The following is a description of a gene set: from publication Qi Q, Cavanagh MM, Le Saux S, Wagar LE, Mackey S, Hu J, Maecker H, Swan GE, Davis MM, Dekker CL, Tian L, Weyand CM, Goronzy JJ (PMID 27764254) species: Homo sapiens Vaccination with attenuated live varicella zoster virus (VZV) can prevent zoster reactivation, but protection is incomplete especially in an older population. To decipher the molecular mechanisms underlying variable vaccine responses, T- and B-cell responses to VZV vaccination were examined in individuals of different ages including identical twin pairs. Contrary to the induction of VZV-specific antibodies, antigen-specific T cell responses were significantly influenced by inherited factors. Diminished generation of long-lived memory T cells in older individuals was mainly caused by increased T cell loss after the peak response while the expansion of antigen-specific T cells was not affected by age. Gene expression in activated CD4 T cells at the time of the peak response identified gene modules related to cell cycle regulation and DNA repair that correlated with the contraction phase of the T cell response and consequently the generation of long-lived memory cells. These data identify cell cycle regulatory mechanisms as targets to reduce T cell attrition in a vaccine response and to improve the generation of antigen-specific T cell memory, in particular in an older population. Human Gene Set: QI_PBMC_ZOSTAVAX_AGE_50_75YO_CORRELATED_WITH_CONTRACTION_OF_VZV_SPECIFIC_T_CELLS_PEAK_TO_28DY_AT_1DYPOSITIVE Genes positively correlated with contraction of VZV specific T cells (peak to 28d) in peripheral blood mononuclear cell in seniors (50-75) after exposure to Zostavax, time point 1D, and this is the list of marker genes: TM2D3, MYH9, WAC, TMEM140, ERGIC1, DPYD, SOD2, ADPRS, HLA-DRB3, DENND5A, TSC22D3, NIBAN1, TMBIM1, RFTN1, SARAF, GABARAPL2, SELL, GPC1-AS1, SEC14L1, ACAP2, AMY2A, SMNDC1 (survival motor neuron domain containing 1), FOXO3, KHDC4, ATP6V1B2, PCBP1, POGK, CLINT1, NOTCH1, ALDH2, TOMM20, RNF40, CAP1, ITGB2 (NCBI Gene Id 3689), WAS, LRRK2, TMEM179B, NAAA, MAN2B2, LILRA6, KDM3B, CTNNA1, BANP, CXCR2, ANTXR2, WBP2, TMED7 (NCBI Gene Id 51014), PRR13, PPT1, RBM47, RERE (arginine-glutamic acid dipeptide repeats), SIGLEC10, RNF114, GRN, ARAP3, NCOA4, RNF103, NARF, TALDO1, VPS26B, ZHX2, HHEX, PGAM1, KDM2B, RNASET2, UBAP1, SDF4, TLR1, GATD3, CAMK2G, THUMPD1, PCMTD1, IST1, PPP1R21, MTMR3, EFTUD2, CYBB, NUP93, CITED2, LIMS1, FRAT1, HNRNPA2B1, CLEC16A, PSMB10, SH3GLB1, FNBP1, TIPARP, UVSSA, RNF130, HDAC1, RNF149, DNAJB6 (NCBI Gene Id 9186), PTBP1, ESS2, MYADM, CREBBP, CYSLTR1, MED16, SH3KBP1, HMGB2, L3MBTL2, ZNF217, ADD1, PRKCB, NFE2, PPP4R1, RBL2, RTF2, CD14, RAB11FIP1, SPEN, DIP2B, WDR1, MARCKS, ALOX5 (NCBI Gene Id 240), IRF2BP2, TRIP12, UBA7, LCP1, RIPOR1, KIF5B, CPQ, ST6GAL1, POTEF, CHST15, WDR37, TAGLN2, SLCO3A1, SMAP2, MORC2-AS1, PARP1, NPL, CFAP58, RBM33, NABP1, SELENOS, TMEM87A, SHCBP1, FGR, ROCK2, GNAI2, TLR4, DCAF12 (DDB1 and CUL4 associated factor 12), ST13P4, TUBB, TTC27, HERPUD1, AP1M1, CALM2, YIPF6, SLC6A6, CPSF1, YBX3, ZC3H7A, GAB2 (NCBI Gene Id 9846), RB1CC1, PGRMC2, ITGB1BP1, MTMR14, ABHD5, RNF13 (NCBI Gene Id 11342), CLIC4, CD300A, CMIP, TNFRSF1A, NACA, SERF1B, TMEM158, PLSCR1, GDI2, ZC3H4, SRSF5, FNDC3B, RNF34, MORF4L1, EIF4E3, FBXO33, PGAM4, TRMT5, ZC3HAV1, SIGLEC14, IK, RNF19A, CTDSP2, CAPNS1, TNFRSF1B, RNF145, CDC42, JARID2, ERICH1, ADGRE5, VSIR, IGF2BP2, CAB39, RXRA, RAC2, SPAG9, TXK, RHOG, STX4, GTPBP4, ZMIZ1, CYBA, CD300LF, ADGRE2, CPVL, WLS, AKIRIN2, EIF4A3, YWHAB, HARS2, LPAR2, RUNDC1, STAT3, PDE7A, ZFAND5, ARHGDIB, HLA-DRA, PSAP, CHD1, BTF3, RALBP1, TGFBR2, SLA, BTN2A1, NCOA1, SLC7A5, JAK1, FOS, LRP10, SGK1, CCR2, BNIP3L, RESF1, CLNS1A, EIF3L, IFIH1, PSME4, PLCG2, GAS7, ARHGAP25, SDE2, PCBP2, MLKL, CYTIP, HSPA1A, NKTR, NCF1C, SP3, ELF2, MMP25, ARHGAP30, TRIM58, HCFC1, UBE3C, RAB24, TFDP1, PRKCD, SCAF11, RAF1, GAB3, SERPINA1, ADGRE3, FBXO7 (F-box protein 7), EMILIN2 (elastin microfibril interfacer 2), PTBP3, HLA-B, DCAF7, PDLIM7, PHIP (NCBI Gene Id 83843), DERL1, GLB1, B4GALT5, FCGR3B, TNFAIP6, LMO2, SON, GIMAP8, NUCB1, ARF1, TACC1, TCN1, ARID1A, EXO5, IWS1, NOMO1, ARPC5, SNCA, SNRK, RRBP1, ADAR, SYPL1, UBC, NCOA6